The following is a description of a gene set: Axial dystonia A type of dystonia that affects the midline muscles, i.e., the chest, abdominal, and back muscles. Human Gene Set: HP_AXIAL_DYSTONIA studied in species Homo sapiens, and this is the list of marker genes: COL6A3, ALS2 (NCBI Gene Id 65058), PLA2G6, COQ2, NDUFS3, MAPT, FUS, CIZ1, SIGMAR1, SPTLC1, PPP2R2B, MECR, EIF2AK2, HPDL, GNAL, SPG11